Given this list of marker genes Gja1, Tubb4a, Tuba1b, Tuba4a, Tuba8, Tuba1a, Tuba1c, Tubb2b, Tubb4b, Tuba3b, Gjb2 (gap junction protein, beta 2), Tubal3, Tubb6, here is a description of the gene set: part of: Gap junction assembly electronically inferred by orthology from the curated human pathway Reactome Pathway: Transport of connexons to the plasma membrane This event has been computationally inferred from an event that has been demonstrated in another species.<p>The inference is based on the homology mapping from PANTHER. Briefly, reactions for which all involved PhysicalEntities (in input, output and catalyst) have a mapped orthologue/paralogue (for complexes at least 75% of components must have a mapping) are inferred to the other species. studied in species Mus musculus